Given this list of marker genes Camk2b, Actn2, Kcnj11, Aldh5a1, Lrfn4, Adcy1, Vamp2, Kcnk16, Dlgap2, Rtn3, Slc6a4, Chrna7, Syn2, Hcn4, Kcna7, Gja10, Dnajc5, Cacna1b, Kcnj4, Lrfn3, Cacng3, Kcnh8, Slc1a3, Plcb2, Kcng4, Rps6ka3, Pick1, Grik3, Slc1a2, Kcnab1, Cacnb2, Kcnj10, Prkaca, Camk2a, Chrna9, Gabrb3, Ap2b1, Lrrtm3, Kcnk6, Cask, Gng7, Dlgap1, Myo6, Gnb5, Gls2, Htr3a, Chat, Kcnk10, Hspa8, Ptprf, Prkacb, Cacng2, Grin3a, Gabrr2, Gng8, Kcng2, Akap5, Gabbr2, Gngt2, Gria4, Chrna3, Kcnc2, Gng4, Flot1, Gnai3, Arl6ip5, Kcnmb2, Nlgn3, Abcc8, Chrnb4, Lrrtm4, Epb41l5, Kcnb2, Rims1, Slc6a1, Grin1, Nlgn4l, Kcna10, Lrrc7, Plcb3, Adcy4, Kcnn4, Kcnh7, Cacna1e, Kcnj8, Gabra6, Shank1 (SH3 and multiple ankyrin repeat domains 1), Unc13b, Gria2, Kcnj12, Camk1, Gnb1, Ppfia1, Il1rapl1, Cacnb3, Dlg2, Kcnk9, Rps6ka2, Kcnmb3, Kcnd2, Gabrq, Gjc1 (NCBI Gene Id 353069), Kcna5, Adcy5, Slitrk4, Camk2g, Kcnj6, Gng5, Rps6ka6, Grin2c, Kcnk13, Arhgef9, Kcnv1, Gnb4, Slc18a2, Epb41, Kcnmb4, Slc38a1, Prkar1a (protein kinase, cAMP dependent regulatory, type I, alpha), Shank3, Slc6a13, Slc32a1, Adcy8, Chrna6, Kcnc1 (NCBI Gene Id 320399), Htr3b, Cplx1, Calm1, Gng11, Gabbr1, Chrne, Gnai2, Tomt (NCBI Gene Id 791260), Slitrk1, Calm2, Stx1a, Adcy9, Ncald, Gad2, Prkcb, Abcc9, Camkk2, Gabrr1, Kcna4 (potassium voltage-gated channel, shaker-related subfamily, member 4), Lin7c, Gabrg2, Kcnj5, Gabra5, Ap2m1, Adcy6, Kcnj14, Kcnk4, Grip1, Kcnd1, Gabrb1, Gabra4, Kcnj2, Kcnk1, Lrrtm1, Chrna2, Kcnh5, Kcnab2 (potassium voltage-gated channel, shaker-related subfamily, beta member 2), Kcnh4, Ptprd, Kcnh1, Kcnk2, Sorbs2, Slitrk5, Rps6ka1, Adcy2, Epb41l2, Syn1, Slc6a3, Kcnn3, Kcna1, Kcng1, Slc1a7, Grik5, Gabrb2, Gabra1, Glul, Slc22a1, Gabrg3, Syt1, Ntrk3, Kcng3, Aldh2, Creb1, Chrnb3, Kcnh2, Kcnj15, Gng2, Gria1, Chrnb2, Chrna5, Lin7a, Ap2a2, Grik4, Kcna6, Homer1, Camk2d, Kcns1, Adcy3, Chrnd, Grm5, Ppfia3, Gabra3, Cacna2d3, Glra3, Kcnc4, Gngt1, Hcn3, Gls, Ppfia4, Kcnc3, Lrfn2, Grin2a, Glrb, Cacng8, Slitrk6, Adcy7, Kcnq5, Tspoap1, Kcnj9, Nsf (NCBI Gene Id 18195), Maoa (monoamine oxidase A), Il1rapl2, Dlg3, Slc38a2, Kcnh3, Nefl, Glra1, Nlgn1, Kcnj1, Cacna1a, Gabrr3, Rab3a, Epb41l3, Kcna2, Hcn2, Tspan7, Gabra2, Hcn1, Nrxn3, Ptprs, Lrrc4b, Ppfibp1, Mdm2, Ppfia2, Kcnb1, Ap2s1, Slc5a7, Kcnv2, Gnal, Homer2, Kcns2, Cacnb4, Gng3, Camkk1, Panx2, Kcnn1, Dlg1, Kcnab3, Gad1, Slc22a2, Slc17a7, Calm3, Lrrtm2, Kcnk3, Flot2, Kcnq4, Homer3, Dlg4, Ppfibp2, Panx1, Slc18a3, Lin7b, Slitrk3, Il1rap, Grik1, Kcnk18, Chrng, Apba1, Grip2, Prkcg, Grin2d, Snap25, Prkar1b, Kcnj3, Kcnq1, Syn3, Dlgap3, Gnb2, Gnat3, Nrxn1 (neurexin I), Cacna2d2, Abat, Gjd2, Gng10, Stxbp1, Plcb1, Naaa, Kcnf1, Gnai1, Cacng4, Grik2, Cacnb1, Grm1 (NCBI Gene Id 74875), Chrna1, Slc1a6, Kcnj16, Lrfn1, Slc6a12, Nrxn2, Gnb3, Kcns3, Glra2, Gng12, Ap2a1, Gria3 (glutamate receptor, ionotropic, AMPA3 (alpha 3)), Kcnk7, Slc6a11, Comt, Gng13, Kcnd3, Slc1a1, Kcna3, Dlgap4 (NCBI Gene Id 98882), Nlgn2, Kcnh6, Slitrk2, Chrna4, here is a description of the gene set: studied in species Mus musculus Mouse Gene Set: REACTOME_NEURONAL_SYSTEM Neuronal System